The following is a description of a gene set: species: Homo sapiens Human Gene Set: GOBP_MRNA_PROCESSING Any process involved in the conversion of a primary mRNA transcript into one or more mature mRNA(s) prior to translation into polypeptide., and this is the list of marker genes: RNVU1-8, THOC5, LSM5, RNVU1-19, SNRPD2, SNRPG, RNU2-1, RNVU1-14, C1QBP, PRMT7, SRSF9, ARGLU1, TUT1, APOBEC1, USP49, SLTM, LSM2, FMR1, RNU5B-1, ESRP1, CELF5, ADARB2, RNVU1-3, SSU72L5, MBNL3, APOBEC2, AKAP8L, DDX47, ZC3H14, MYOD1, THRAP3, WBP11, SSU72L3, NUDT21, GRSF1, RBM15, SDE2, SMN1 (survival of motor neuron 1, telomeric), NCBP2, WEE2-AS1, SRRM4, TENT4B, ZNF830, ALKBH5, METTL14, CCAR2 (cell cycle and apoptosis regulator 2), SNRNP200, SRSF1, DHX16, CPSF6, ISY1, SRPK1, SLC39A5, THOC6, ANGEL2, USP4, SREK1IP1, RSRC1, FAM50A, RNU5D-1, GCFC2, RBBP6, LSM8, RPRD2, RNU6-7, RBMXL2, LUC7L, SRSF6, CRNKL1, SNRNP25, PPIH, CBLL1, PRPF40A (pre-mRNA processing factor 40 homolog A), TSEN2 (NCBI Gene Id 80756), PTCD2, SCAF11, PAN2, NCL, ERN2, ELAVL4, RBMY1F, DDX39A, DDX46, SF3A1, SRSF7, TRMT2A, HNRNPA3, CDK13, TRMT61B, TTF2, ZNF473, RNU5A-1, CLASRP, DDX1, PRPF8, SRRM2, PRPF19, UBL5, ZMAT5, FIP1L1, SNRPC, C9orf78, KAT8, EFTUD2, PTBP1, SF3A3, RBMY1B, ZFP36L1, RBPMS2, RPRD1A, THUMPD2, HDAC7, NCBP2L, HTATSF1, QKI (NCBI Gene Id 9444), DHX35, RBMY1A1, RAMAC, SMN2, TRA2B, TRUB1, RBM10, CD2BP2, RBM42, SFSWAP (NCBI Gene Id 6433), TIA1, RNU6ATAC, TCERG1, HABP4, RBMXL3, PPIL2, CELF6, CDC5L, MAGOHB, SRSF8, ZBTB7A (NCBI Gene Id 56976), JMJD6, MTREX, SNU13, NOL3, CPSF4, ARMC7, HNRNPR, U2AF1L4, PRPF31, RBM3, SART3, PDE12, HSF1 (NCBI Gene Id 642255), PAXBP1, SNRPF, PAPOLB, RBM24, SLU7, STH, RNGTT, SNRPA, HNRNPC, ZNF326, PPIL3, PABPC1, IVNS1ABP, NONO, PPP1R8, LSM1, HOXB-AS3, ZC3H3, PUF60, DHX15, LSM6, THOC2, ADAR, TARDBP, LSM7, GPKOW, TSEN54, NPM1, RBMY1D, CSTF2, RALY, ZMAT2, ZC3H13, PPIL1, HNRNPU, AAR2, HNRNPA1L3 (heterogeneous nuclear ribonucleoprotein A1 like 3), SUGP1 (SURP and G-patch domain containing 1), LSM3, USP39, NRDE2, CWC15 (NCBI Gene Id 51503), PNPT1, LSM10, BUD13, RBM22, SUGP2, APOBEC4, HNRNPA0, TENT2, ARB2A, YJU2B, CDK12, PRKACA, TSSC4, VIRMA, WDR77, CELF4, CELF3 (NCBI Gene Id 11189), H2AB1, WDR83, RBM44, PCIF1, XAB2, TRMT6, SYF2, PAPOLG, DDX42, SFPQ, RPUSD3, EIF4A3, HNRNPLL, SNRPA1, PRPF38A, EXOSC10, SNRPN (NCBI Gene Id 6638, small nuclear ribonucleoprotein polypeptide N), NSRP1 (NCBI Gene Id 84081), MYG1, CDC73 (NCBI Gene Id 79577), RBM20, UPF3A, DHX9, RBM15B, RNU11, KHDRBS1, RNPS1, BUD31, YJU2, AFF2 (ALF transcription elongation factor 2), HSPA8, SF3B1, TXNL4B, TSEN15, RPUSD2, DDX17, SNRNP35, RBMY1J, ZPR1, ARVCF, ARL6IP4 (ADP ribosylation factor like GTPase 6 interacting protein 4), SRSF3, ILF3, CCNB1, CIR1, CELF1, ZRSR2P1, CWF19L2, THOC3, PRPF6, PRPF3, RBFOX3, RBM17, CWC27, HNRNPH3, SNRNP70, HNRNPA2B1, SAP18, RBMX, CELF2, SRRM1, PRPF38B, RNF113A, SYMPK, DDX39B, FBXO24, SETX, TAF12-DT, KHSRP, TRA2A, RNU5F-1, CPEB1, HNRNPH1, PQBP1, SSU72L2 (NCBI Gene Id 650536), DCPS, SNW1 (SNW domain containing 1), RNU5E-1, YTHDC1 (NCBI Gene Id 91746), RNVU1-15 (NCBI Gene Id 105373467), TRMT10C, TRUB2, SRSF4, LUC7L2, MBNL2, GEMIN8, PUS1, LUC7L3, MBNL1, MTPAP, RSRP1, PRPF4, RBM39, PRPF40B, SRSF2, SSU72L4, PNN, SNRNP40, PUS7L, KHDC4, RNVU1-1, RNVU1-4, BRDT, ESS2, LSM4, RNMT, TBRG4, RBM14, RPUSD4, CSTF3, CLP1, HNRNPUL2, DNAJC17, RNU6-1, CPSF7, PTBP3, CHD8, HNRNPK, SNRPD3, CSTF1, CDK11A, CSDC2, SSU72L6, LARP7, PRMT9, IWS1, RNASEL, RBM4, DHX36, STRAP, CPSF3, RRP1B (NCBI Gene Id 23076), SF3B6, RBM11, KHDRBS3, RNVU1-17, TGS1, GEMIN6, WBP4, NUP98, ZCCHC8, TENT4A, RBM23, SRSF11, AQR, RBM28, RBFOX1, RNU1-4, AHCYL1, CASC3, FRA10AC1, A1CF, CWC22, SF3B4, RBMX2, GEMIN4, RBM8A (NCBI Gene Id 9939), METTL3, SNRPD1, PPP4R2, SRSF10, DDX5, CTNNBL1, CWF19L1, PTBP2, NBDY, MAGOH, ZRANB2, BCAS2, INTS15, SNRNP27, GEMIN2, RBM6, DHX8, DHX38, CDC40, YBX1, PCBP4, RBM4B, AKAP17A, COIL, SRPK3, DHX40 (DEAH-box helicase 40), FASTKD5, IK, RNVU1-7, ZCRB1, SART1, DDX23, CDK9, PUS7, SAFB, RBPMS, NSUN2, ACIN1, SNRPGP15, DUS3L, HNRNPF, SSU72, SF3B5, SF3B3, THOC1, U2AF1, HNRNPM, RBM41, CMTR2, BARD1, AICDA, LSM11, PAN3, PRKRIP1, RBM25, SNRPE (NCBI Gene Id 6635), CMTR1, RBFOX2, LEO1, RBMY1E, SCNM1, ALYREF, LGALS3, METTL16, CLNS1A, RNU4-1, PRDX6, MFAP1, PRMT5, XRN2, SNIP1, ADARB1, RNU6-9, UPF1, RBM47, SRPK2, SYNCRIP, RNPC3, CNOT6L, HMX2, RBM38, CPSF1, WTAP (NCBI Gene Id 9589), SMU1, RNVU1-2A, PSIP1, DAZAP1, PRPF39 (pre-mRNA processing factor 39), SNRNP48, THOC7, TXNL4A, KHDRBS2, RNVU1-6, WDR33, HNRNPUL1 (NCBI Gene Id 11100), SCAF1 (NCBI Gene Id 58506), GPATCH1, RBM48, PHF5A, CWC25, HNRNPA1, PPIE, MBLAC1, SRSF5, RBM5, SF1, RNU4ATAC, CPSF2, PPWD1, CIRBP, SF3B2, GEMIN7, CACTIN, ZRSR2, PAF1, SMNDC1, PAPOLA, GEMIN5, RBM7, NCBP1 (NCBI Gene Id 4686), GPATCH8, PABPN1, SSU72L1, FRG1, PLRG1 (NCBI Gene Id 5356), CSTF2T, DBR1, ECD, H2AB2, SNRPB2, NOVA1, KIN (NCBI Gene Id 22944), SREK1, SLBP, PRPF18, ERN1, NOVA2, SUPT6H, RBMXL1, UPF3B, SRSF12, CENATAC, SF3A2, DDX20, U2AF2, HNRNPA1L2, CDK11B, SNRPB, DDX41, ESRP2, DYRK1A, PPARGC1A, TRMT61A, RPRD1B, PRP4K, CRIPT, TFIP11 (NCBI Gene Id 24144), SON, PCF11, REST, SAFB2, HNRNPL, TSEN34, H2AB3, RNU4-2, NCBP3